The following is a description of a gene set: species: Homo sapiens The lysis or structural demise of the corpus luteum. During normal luteolysis, two closely related events occur. First, there is loss of the capacity to synthesize and secrete progesterone (functional luteolysis) followed by loss of the cells that comprise the corpus luteum (structural luteolysis). Preventing luteolysis is crucial to maintain pregnancy. Human Gene Set: GOBP_LUTEOLYSIS, and this is the list of marker genes: NOTCH1, CASP3, MMP19 (matrix metallopeptidase 19), SLIT2, SLIT3, CASP2, ROBO2, NOTCH4